Given this list of marker genes COL3A1, C1QTNF3, TTPA, FABP7, PAX1, NEUROD1, CKB, SERPINF1, RSPO1, TMEM98 (transmembrane protein 98), UNC5A, TPPP3, HOXD11, COL26A1, OXCT1, METRN, LHX9, here is a description of the gene set: Genes down-regulated in 9.5 days post coitus (dpc) embryos with COMMD1 knockout and in normal 8.5 dpc embryos compared to normal 9.5 dpc embryos. species: Mus musculus from publication van de Sluis B, Muller P, Duran K, Chen A, Groot AJ, Klomp LW, Liu PP, Wijmenga C (PMID 17371845) Human Gene Set: VANDESLUIS_COMMD1_TARGETS_GROUP_4_DN COMMD1 (previously known as MURR1) belongs to a novel family of proteins termed the copper metabolism gene MURR1 domain (COMMD) family. The 10 COMMD family members are well conserved between vertebrates, but the functions of most of the COMMD proteins are unknown. We recently established that COMMD1 is associated with the hepatic copper overload disorder copper toxicosis in Bedlington terriers. Recent in vitro studies indicate that COMMD1 has multiple functions, including sodium transport and NF-kappaB signaling. To elucidate the function of Commd1 in vivo, we generated homozygous Commd1 null (Commd1(-/-)) mice. Commd1(-/-) embryos died in utero between 9.5 and 10.5 days postcoitum (dpc), their development was generally retarded, and placenta vascularization was absent. Microarray analysis identified transcriptional upregulation of hypoxia-inducible factor 1 (HIF-1) target genes in 9.5-dpc Commd1(-/-) embryos compared to normal embryos, a feature that was associated with increased Hif-1alpha stability. Consistent with these observations, COMMD1 physically associates with HIF-1alpha and inhibits HIF-1alpha stability and HIF-1 transactivation in vitro. Thus, this study identifies COMMD1 as a novel regulator of HIF-1 activity and shows that Commd1 deficiency in mice leads to embryonic lethality associated with dysregulated placenta vascularization.